The following is a description of a gene set: Human Gene Set: GOMF_CYSTEINE_TYPE_EXOPEPTIDASE_ACTIVITY Catalysis of the hydrolysis of C- or N-terminal peptide bonds in a polypeptide chain by a mechanism in which the sulfhydryl group of a cysteine residue at the active center acts as a nucleophile. species: Homo sapiens, and this is the list of marker genes: ACTMAP, MINDY2, SCRN2, SCRN3, BLMH, ATG4D, SCRN1, CTSZ, MINDY1